Given this list of marker genes YWHAH, 3a, EP300, N, YWHAG, UBE2I, CAV1, SP1 (Sp1 transcription factor), PSMC6, YWHAZ, PDPK1, YWHAQ, SFN, SMAD3, SMAD4, YWHAB, SERPINE1, M, YWHAE, here is a description of the gene set: Reactome Pathway: SARS-CoV-1 targets host intracellular signalling and regulatory pathways studied in species Homo sapiens part of: SARS-CoV-1-host interactions Severe acute respiratory syndrome coronavirus type 1 (SARS‑CoV‑1) encodes several proteins that modulate host intracellular signaling and regulatory pathways. Among them are nucleocapsid N, membrane M and 3a proteins that directly bind to host targets associated with SARS‑CoV‑1 infection and cytokine production. First, SARS‑CoV‑1 M binds to 3‑phosphoinositide‑dependent protein kinase 1 (PDPK1) to inhibit PKB/Akt activation. Second, SARS‑CoV‑1 N binds to SMAD3 to alter transforming growth factor‑β (TGF‑β) signaling. This interaction prevents SMAD3 from complexing with SMAD4, thereby blocking TGF-β-sensitized apoptosis. The association of N with SMAD3 also enhances the TGF-β-induced expression of PAI-1 (SERPINE1) promoting tissue fibrosis. Third, N protein binding to proteasome subunit p42 (PSMC6) modulates proteasome‑regulated degradation of proteins. Fourth, SARS‑CoV‑1 N binds SUMO-conjugating enzyme UBC9 (UBE2I) to regulate the activity of UBE2I, affecting downstream signaling factors involved in the cell cycle, in addition to its function in the process of sumoylation. Finally, binding of viral 3a to the regulator and scaffolding protein caveolin‑1 (CAV1) may regulate virus uptake as well as the trafficking of viral structural proteins.